Given this list of marker genes BMP4, FGF8, HMGB1, DEFB130B, ALKBH1, HMGB2, FGF10, DEFB104B, PDGFB, DEFB133, CX3CL1, CCL5, DEFB110, VEGFC, CCL16, FGF2, WNT5A, DEFB114, DEFB103A, DEFB103B, COLEC10, DEFB130A, LGALS3, SCG2, GPNMB, CXCL10, FGF7, DEFB104A (defensin beta 104A), S100A4, CCL2, VEGFD, DEFB4A, GDNF, NTF3, VEGFA, HGF, CCL15, PGF, MIF, CCL3, VEGFB, DEFB109B, APP, here is a description of the gene set: studied in species Homo sapiens Human Gene Set: GOMF_CHEMOATTRACTANT_ACTIVITY Providing the environmental signal that initiates the directed movement of a motile cell or organism towards a higher concentration of that signal.